The following is a description of a gene set: studied in species Homo sapiens Genes down-regulated in common lymphoid progenitor versus pro-B cells. from publication Ramirez K, Chandler KJ, Spaulding C, Zandi S, Sigvardsson M, Graves BJ, Kee BL (PMID 22608498) Human Gene Set: GSE37301_COMMON_LYMPHOID_PROGENITOR_VS_PRO_BCELL_DN Expression profiling of Rag2-deficient Ets1++ and Rag2-deficient Ets1-- mature NK cells and WT bone marrow progenitors, WT T cells, and WT Pro B cells, and this is the list of marker genes: EXOC3, ADGRB1, HAX1, HSPA1L, USP2, STMN1, GNAQ, SPATS2L, SMAD2, MANF, RAD51, APPL1, CNN2, GGNBP2, EPS8L2, ATP5MF, MKNK1 (NCBI Gene Id 8569), CHAF1A, SUMO2, RANGRF, TRPM2, PLSCR3, OARD1, WSB2, MMUT, RAD54B, IFITM2, FBXL14, BPGM, RAP1GAP2, KCNK15-AS1, RCOR3, STAU2, RBMX2, PIGB, RCHY1, BLVRA, DHCR24, ATP6V1H, NFATC3, CKS1B, ARPP19, VBP1, RALY, PIP4K2C, SIGIRR, KIF14, MCM2, WDR41, NXT2, PTGDR, HERC2, RIBC2, COQ3, ORC5, IQGAP1, TMEM204, BIRC5, VPS26A, TYROBP, ACOT8, ACOT7, GLO1, NDUFS4, ACTB, TOPBP1, TDRD3, UPF3A, TAPBPL, DENND4C, YTHDC2, RTN3, CLEC2B, ARPC5, MAGT1, COX5B, ICAM3, FLT3LG, CTSC, PHF20, ATP5F1C, ARHGEF6, TBXAS1 (NCBI Gene Id 6916), FDFT1, SYCP2, MRPL40, NHLRC2 (NHL repeat containing 2), GPAA1, CCDC92 (NCBI Gene Id 80212), LAMP2, RAD52, NEK2 (NIMA related kinase 2, NCBI Gene Id 4751), STX7, CPNE1, VAMP8, PML, SYT13, IQGAP2, SGSH, RAB6A, SERINC3, SMIM8, ADCK2, VPS41, SEPTIN2, FBXO5, EFCAB14, MYL12B, MMP25, ANKZF1, SLC33A1, CHFR (NCBI Gene Id 56732), CIZ1, TMEM41B, P2RY10, NMI, SRPK2, ATP9B, TARP, HMOX2, SPTLC1, HMHB1, TCFL5, IP6K1, SKP2, UBE2K, TROAP, KIF26B, KYAT3 (kynurenine aminotransferase 3), FLI1, LXN, UBL4A, ATP5ME, DOK1, PCTP, WWC3, PYHIN1, IDH1, CCNG1, IL15, UGDH, GMNN, MXD4, CRLF3, SCAI, HAUS4, ZNHIT1, FAN1, LEMD3, ZNF45, CEP135 (centrosomal protein 135), TSPAN14, ELMO1, KCNA3, ATP5MC2, ZCCHC4, IDH2, SPG11, RBBP7, AKT1 (AKT serine/threonine kinase 1), CRYL1, ATP11B, CDT1, DNMT1 (DNA methyltransferase 1), KIDINS220, GCC2, NSD2, BARD1, PSMC5, PPP2R1A, BST2, INPP5D, DENND1B, ATP5MG, SCAPER, CBR3, NVL, KNL1, ASF1B, ARAP3, MRE11, ACTA2, CDK13 (cyclin dependent kinase 13), ZNF446, ADD3, NMRK1, CCNA2, GSTP1, ZBTB38, DEK, AP2S1, ZNF652, NKTR, MRPL13, MAEA, ANXA4, RRM1, MYOC, BNIP3L (NCBI Gene Id 9257), ZNF43 (zinc finger protein 43)